Given this list of marker genes Gm6040, Ccl27b, Defb37, Ccl6, Defb46, Ccl19-ps4, Ccl24, Ccl27al, Ccl7, Creb3, Msmp, Defb1, Jak1, Ccl25, Ccl4, Defb39, Ccl20, Ccl11, Defb5, Defb9, Defb15, Ccl19-ps6, Cxcl13, Defb48, Ccl19-ps5, Ccl19-ps3, Cx3cl1, Ccl26, Ccl8, Defb3, Ccr2, Defb8, Defb10, Ccl3, Ccl21a, Ccl2, Defb6 (defensin beta 6), Ccl27a, Ccl17, Nes, Defb7, Ccl21b, Defb38, Defb33, Stat1, Ccl22, Ccl19, Defb40, Xcl1, Defb34, Nup85, Defb4, Ccl1, Defb11, Cnih4, Defb14, Ccl12, Ccl5, Ccrl2, Defb47, Ccl9, Defb2, Ccl19-ps1, Nars1, Stat3, here is a description of the gene set: studied in species Mus musculus Binding to a CCR chemokine receptor. Mouse Gene Set: GOMF_CCR_CHEMOKINE_RECEPTOR_BINDING